The following is a description of a gene set: species: Mus musculus The region of a polarized cell that forms a tip or is distal to a base. For example, in a polarized epithelial cell, the apical region has an exposed surface and lies opposite to the basal lamina that separates the epithelium from other tissue. Mouse Gene Set: GOCC_APICAL_PART_OF_CELL, and this is the list of marker genes: Adrb2, Reep6, Psg26, Nos3 (NCBI Gene Id 71933), Snx10, Tnik, Pard3b, Fzd6, Cubn, Tjp1, Clcnka, Dync2h1, Slc22a18, Mlc1, Slc22a19, Hspa1b, Cldnd1, Slc2a7, Slc47a2, Pappa2, Slc46a1, Eps15, Cd55, Atp1a1, Itpk1, Scnn1g, Dpep1, Igsf5, Scrib, Slco2b1, Atp7a, Tlr9, Epcam, Slc7a11, Zpld2, Slc9a1, Epb41l4b, Sipa1l3, Rapgef2, Psg27, Slc15a1, Clic4, Atp1b3, P2ry6, Hax1, Slc2a9, Aqp5, Adam17, Pth1r, Atp12a, Dsg1b, Tubg1, Psg23, Slc5a1, Hvcn1, Hamp, Ceacam11, Duoxa2, Homer1, Cyp4f18, Egfr, Rdx, Nrg1, Slc9b2, P2rx2, Anxa4, Sorbs2, Drd3, Slc7a13, Tgfbr1, Pakap, Klk1, Slc5a3, Bst2, Car12, Nedd1, Slc5a11, Abca7, Slc16a2, Slc6a18, Slco3a1, Atp1b2, Slc26a6, Osmr, Slc6a14, Il10ra, Slc14a2, Msn, Iqgap1, Numb, Rab17, Cd81, Nherf1, Slc1a1, Pten, Tmem30a, Hspa1a (NCBI Gene Id 193740), Prkaa2, Dll1, Ceacam3, Abcg2, Mfrp, Slc11a2, Cybrd1, Cetn2, Slc4a7, Prkg2, Fap, Cd9, Havcr1, Slc23a2, Cyp4f15, Mgst1, Kcnma1 (potassium large conductance calcium-activated channel, subfamily M, alpha member 1), Slc26a4, Slc22a8, Myo6, Slc7a9, Tmem114 (transmembrane protein 114), Slc34a3, Bmpr2, Slc26a11, Cib1, Usp9x, Ano1, Cyp4a31 (cytochrome P450, family 4, subfamily a, polypeptide 31), Cripto, Ddr2, Grk2, Slc26a2, Zmynd10, Slc29a1, Itgb3, Eda, Gm2a, Acp3, Actg1, Folr1, Plb1, Cav1, Bysl, Fabp1, Anxa6, Atp2b1, Abcb1b, Vash1, Ctsl, Frmd6, Wdpcp, Atp2b2, Adgrg2, Atp6v1g1, Hsp90ab1, Slc22a12, Slc16a1, Trpv4, Slc5a2, Septin7, Klk1b4, Cldn1 (NCBI Gene Id 12737), Shroom4, Aspm, Ifitm3, F2rl2, Prkcz, Dstyk, Psg20, Myrip, Slc5a8, Duox2, Kcna5, Thy1, Slc34a2 (solute carrier family 34 (sodium phosphate), member 2), Slc5a7, Kcnk1, Crb1, Cftr, Slc22a21, Plet1, Igfbp2, Kiss1, Kcnn4, Slc39a10, Gpr143, Klk1b26, Plpp1, Tek, Cspg4, Gnas, Cdh1, Aqp8, Tomt, Hip1r, Prkca, Abcc2, Prkab2, Slc13a2, Itga8 (NCBI Gene Id 98963), Birc5, Rab27b, Slc26a7, Fas (NCBI Gene Id 14102), Ajm1 (NCBI Gene Id 381353), Akap7, Ager, Crb2, Kl, Edar, Kcnb1, Rab14, Gjb6, Ctsk, Ptpro, Pdia3, Cd300lg, Stk26, Slc22a3, Patj (PATJ, crumbs cell polarity complex component), Pebp1, Anxa1, Clic5, Abcb4, P2ry4, Clcn5 (chloride channel, voltage-sensitive 5), Slc2a5, Srr, Cyp4a32, Slc34a1, Rapgef4, Slc22a5, Slc12a6, Slc4a5, Plat, Dpp4, Mtcl1, Erbb3, Slc10a2, Slc26a3, P2ry2, Kcne1, Kncn, Prkci, Dab1, Tmem174, Lrp2, Slc16a8, Stxbp3, Slc9a8, Atp6v0d2, Abcg5, Sapcd2, Trf, Stx3, Tmem235 (NCBI Gene Id 546519), Cblif, Lrrc15, Kcnq1, Slc39a6, Marveld2, Gnat3, Prom1, Pcm1, Tjp3, Oxtr, Mip, Dbh, Cyba, Slc36a1, Slc20a2, Lhfpl5, Cyp4a12a, Slc47a1, Kcne4, Slc38a1, Hfe, Cdhr5, Spef1, Cep164, Fn1, Nherf2, Slc23a1, Slc6a19, Upk2, Cnksr3, Pllp, Klk1b9, Adcy8, Atp7b, Trpm6, Ocel1, Dcxr, Muc20, Atp4b, Stk39 (serine/threonine kinase 39), Gpihbp1, Dsg1a, Plec, Vangl2 (VANGL planar cell polarity 2), Acy3, Pld1, Psg29, Umod, Hsd11b1, Pdpn, Pard6g, Slc6a20b, Otog, Fzd3, App, Sptbn5, Fat4, Slc4a9, Abcc6, Dlg1, Slc4a8, Prom2, Ceacam13, Muc4, Erbb2, Arhgef18, Npc1l1, Pfkm, Slc6a9, Gnat1, P2ry1, Dync2li1, Cdhr2, Ptk2, Mal2, Ceacam2, Kcne2, Slc17a5, Nlrp5, Slc7a5, Slc22a1, Akr1a1, Abcc4, Slc39a8, Slc22a4, Slc25a27, Pip (prolactin induced protein), Cacnb3, Cyp4a14, Trpa1, Lzts1, Ush2a, Ecrg4, Ap2a1, Pdgfrb, Klk1b21, Slc17a2, Homer2, Itpr3, Pard6b, Slc12a3, Rapgef3, Reg3b, Vamp3 (NCBI Gene Id 320838), Vldlr, Ceacam1, Myo5b, Hamp2, Cyp4a12b, Lrp1, Nod1, Slc4a11, Fat1, Rab27a, Cd55b, Slc7a12, Upk3a, Slc12a1, Nf2, Ahcyl1, Atp1b1, Cdh2, Amotl2, Cntfr, Kcnk2, Nox4, Enpp3, Il6ra, Ocln, Atp6v1c1, Ren1, Specc1, Slc24a4, Lct, Cyp4f14, Abcg8, Dram2, Ctsb, Slc13a1, Klk1b1, Cd44, Adcy10, Nherf4, Hsp90aa1, Btd, Car2, Atp6v0d1, Ldlr, Crb3, Slc38a3, Myo1a, Psg19, Cldn4, BC034090, Psg21, Ezr, Slc17a1, Mfsd4b1, Atp6ap2, Clca4a, Cdc42, Rab18, Ptprh, Klk1b11, Pals1, Slc2a1, Pde4d, Prkaa1, Atp8b1, Ctnnb1, Ooep, Pdzk1ip1, Mpp3, Slc44a4, Slc26a9, Rhcg, Slc2a13, Lgmn, Ptprq, Cd36, Fxyd1, Atp4a, Casr, Frmpd2, Gabrp, Ceacam20, Slc3a2, Mpdz (multiple PDZ domain crumbs cell polarity complex component), Cldn25, Otoa, Gja1, Cd34, Tchp (trichoplein, keratin filament binding), Stx4a, Slc17a4, Kcnc2, Sptbn2, Atp6v1b2, Svbp, Crhr1, Atp6v1a, Hpn, C1qtnf5, Slc15a2, Abcb1a, Dnaaf11, Asic5, Chrna7, Cyp4a29, Psg28, Slc29a2, Psg17, Mreg, Slc9a2, Shroom3, Aqp2, Dsg2, Stc1, Trpv5, Vcam1, Slc39a14, Slc3a1, Spp1, Slc39a4, Cyp4a30b, Car14, Shroom1, Fabp2, Cldn24, Mal, Sytl4, Shroom2, Dvl2, Slc5a6, Upk1a, Muc17, Slc5a10, Slc9a4, Slc31a1, Atp6v1b1, Rapgef6, Amn, Clcn3, Slc2a2, Slc9a3, Aqp1, Ceacam23, Slc30a5, Slc19a1, Klk1b27, Slc4a10 (solute carrier family 4, sodium bicarbonate cotransporter-like, member 10), Lmo7, Slc22a13, Ptch1, Emp2, Slc12a2, Ripor2, Myo7a, S100g, Klk1b24, Car4, Pdzd2, Afdn, Pkhd1, Adgrf5 (adhesion G protein-coupled receptor F5), Shank2, Klk1b3, C2cd2l, Slc22a2, Slc6a6, Cyp4a10 (NCBI Gene Id 13117), Dab2, Atp6v0a4, Amotl1, Dchs1, Slc29a4, Slc28a1, Ceacam5, Pdzk1, Upk1b, Abcb5, Insc, Pard6a, Scnn1a, Klk1b5, Slc22a7, Pard3, Myo7b, Slc6a8, Cacna1d, Klk1b22, Stxbp2, Myo1b, Naaladl1, Ace2, Acvr1, Hyal2, Slc17a3, Atp6v1e1, Abcc1, Anxa13, Adam7, Jag1, Slc43a1, Slc4a2, Cdh23, Tcirg1, P2rx4, Slc6a20a, Il18, Dsg1c, Podxl, Ajap1, Slc7a8, C5ar2, C5ar1, Slc7a1, Notch1, Nin, Scnn1b, Mtdh, Myl12b, Mgam, Gp2, Enpep, Muc13, Cfap126, Klk1b16, Muc1, Chl1, Slc39a3, Slc16a3, Kcna1, Klk1b8, Abcc5, Ush1c, Otof, Abcb11, Psg25, Myh9, Kcnj10, Slc5a12